The following is a description of a gene set: studied in species Mus musculus A process in which membrane potential cycles through a depolarizing spike, triggered in response to depolarization above some threshold, followed by repolarization. This cycle is driven by the flow of ions through various voltage gated channels with different thresholds and ion specificities. Mouse Gene Set: GOBP_ACTION_POTENTIAL, and this is the list of marker genes: Akap9 (A kinase anchor protein 9), Hcn4, Kcnb1, Kcna5, Calm3, Slc4a3, Ryr2, Kcnmb2, Camk2d, Pmp22, Cacna1h, Kcns1 (K+ voltage-gated channel, subfamily S, 1), Cav3, Trpc4, Chrna4, Gjd2, Snta1, Dsg2, Cacna1i, Scn11a, Nedd4l, Tac1, Slc8a2, Kcnq3, Ctnna3, Kcng3, Hcn1, Ndp, Scn5a, Pawr, Fkbp1b, Cldn19, Grin2a (NCBI Gene Id 14811), Mecp2, Sumo1, Kcnc2, Rapgef4, Atp2a2, Mtnr1b, Trpa1, Dmd, Npr2, Flna, Grin2b, Calm2, Kcnh2, Gna11 (guanine nucleotide binding protein, alpha 11), Ffar3, Kcnd1, Kcnq2, Abcc8 (ATP-binding cassette, sub-family C member 8), Dsc2, Rnf207, Kcng4, Drd1, Myh14, Kcne4, Kcnv2, Cxadr, Nup155 (nucleoporin 155), Chrnb2, Kcnb2, Gpd1l, Nrcam, Cntnap2, Scn4b, Scn9a, Cacnb3, Ywhah, Kcnc1 (potassium voltage gated channel, Shaw-related subfamily, member 1), Bbs10, P2rx7 (NCBI Gene Id 18439), Kcnd2, Nps, Kcnmb3, Scn3a, Kcnma1 (potassium large conductance calcium-activated channel, subfamily M, alpha member 1), Kcnk4, Scn3b (sodium channel, voltage-gated, type III, beta), Mtor, Kcnn2, Kcna4, Chrnb4, Ntrk2, Kcnd3, Kcna7, Gba1, Jup, Kcnmb4, Tnf, Fmr1, Kcna10, Atp1a2 (ATPase, Na+/K+ transporting, alpha 2 polypeptide), Gna15, Slc9a1, Kcnv1, Kcna1, Cln3, Bin1, Cnr2 (NCBI Gene Id 12802), Ank3, Slmap, Dsp, Slco1b2, Kcnf1, Scn2b, Gprin3, Kcna3, Kcnc3, Kcns3, Kcnip1, Gja5, Kcnj2, Cntnap1, Tbx18, Gper1, Gpr88, Gm2990, Cacna2d1, Abcc9, Kcnip2, Fgf12, Grik2, Clcn1, Scn2a, Fgf13, Kcnh6, Scn8a, Ifng, Sod1, Scn10a, Chrna7, Asic5, Kcng1, Kcne5, Kcnk2, Kcna6, Ntrk3, Usp53, Cacna1g, Gnaq, Dcdc2a, Tmem161b, Dlg1, Scn4a, Kcne1, P2rx4 (NCBI Gene Id 52272), Kcne3, Kcnj11, Kcnc4, Cnr1, Kcne2, Kcna2, Gna14, Rangrf (NCBI Gene Id 80408), Ptpn3, Cacna1d, Kcnj5, Gria1, Cav1 (NCBI Gene Id 12389), Foxp1, Adra1a, Cd36, Kcns2, Kcng2, Clcn2, Kcnk9, Kcnq1 (NCBI Gene Id 547397), Scn1a, Dpp6, P2rx1, P2rx2, Chrna5, Cacnb2, Chrna1, Ank2, Scn1b, Cacna1c (calcium channel, voltage-dependent, L type, alpha 1C subunit), Tacr1, Cacnb4, Calm1, Glra1, Hnrnpa1, Pkp2, Kcnj8, Kcnk3, Trpm4, Gpr35, P2rx3